The following is a description of a gene set: species: Mus musculus The directed movement of a motile cell or organism towards a higher concentration of a chemical. Mouse Gene Set: GOBP_POSITIVE_CHEMOTAXIS, and this is the list of marker genes: Ntrk3, S100a7a, Wnt7b, Artn, Met, Mif, F7, Ccr4, Prkca, Casr, Angpt2, Fpr2, Hmgb2, Saa3, Ptgr1, Fgf10 (fibroblast growth factor 10), Vegfd, Pgf, Colec10, Fgf8, Ccl3, Il16, Scrib, Tsc2, F2rl1, Fgf7, Coro1a, Nrp1, Ccl2, Wnt5a (NCBI Gene Id 77565), Sema5a, Kdr, Ccl5, Lrp1, Lgals3, Fgf2, Akt2, S100a4, Vegfb, S1pr1, Vegfa, Smad3, Scg2, Alkbh1, Vegfc, Cdh13, Hgf, Itga2, Lrp2, Angpt1, Cx3cl1, Ptprj, Ntf3, Plxnb3, Cxcl10, Ccl21a, Cxcl12, Hmgb1, Bmp4, Ager, Defb14, Creb3